Given this list of marker genes Arid3b, 1700025G04Rik, Zbtb20, Ugt3a1, Plppr2, Lin28a, Smad3, Plxna4, Ccr10, Fhl1, Dytn, Irf6, Pnpo, Ikzf4, Nfe2, Nynrin (NYN domain and retroviral integrase containing), Smim7, Atf7, Dvl2, Ddx17 (DEAD box helicase 17), Golt1b, Nav1, Hr, Nbea, Ceacam2, Cyp11b1, Aff1, Map3k21, Nfat5, Asb7, Wfdc16, Txn2, Clic5, Pcp4l1, Ovgp1 (oviductal glycoprotein 1, NCBI Gene Id 99799), Erich3, Ddi2, Zfp267, Eno2, Retreg1, Zic2, Arhgef6, Kmt2c, Kcnmb1, Plxna2, Rbm18, Magea8, Arf3, Ino80d, Ceacam1, Hcfc1, Lrrc38, Kmt2b, Bmpr1a, Mlf2, Sptssa, Magea5 (NCBI Gene Id 17141), Mbip, Fam76a, Hipk3, Ldlrad3, Magee2, Wtap, Relch, Nipsnap1, Slc25a15, Rgs8, Braf, Mia3, Plagl2, Pou2af1, Rasl12, Pcgf3, Upk1a, Tmem170b, Rtl5, Txlna, Ltk, Mbd6, Nfix, Lypla1, Psg26, Snx27, Desi1, Abhd5, Shisa7, Etaa1, Camk1d, Dtx4, Nrxn1, Zfp219, Magea1, Myh9, Ccdc85a, here is a description of the gene set: Mouse Gene Set: MIR_3154 Genes predicted to be targets of miRBase v22 microRNA mmu_miR_3154 in miRDB v6.0 with MirTarget v4 prediction scores > 80 (high confidence targets). species: Mus musculus from publication Chen Y, Wang X (PMID 31504780)